The following is a description of a gene set: Human Gene Set: GOBP_MICTURITION studied in species Homo sapiens The regulation of body fluids process in which parasympathetic nerves stimulate the bladder wall muscle to contract and expel urine from the body., and this is the list of marker genes: CHRNA7, CHRNB2, TACR1, CHRNA3, KCNMA1, SCN11A, CHRNB4, UMOD, TRPV1